Given this list of marker genes PYGL, MLLT3, MAPK14, RPUSD2, PLG, SH3BP2, SOX5, STX1A, MITF, TYMP, AQP1, CDKL5 (cyclin dependent kinase like 5), ADRB2, CFI, PIGA, ALB, SERPINC1, IL6, GCNT2 (NCBI Gene Id 880), CAMK2D, AFAP1, NBL1, PDE6A, MFSD9, RGS3, ATP1A2, here is a description of the gene set: Human Gene Set: HOEGERKORP_CD44_TARGETS_DIRECT_UP from publication Högerkorp CM, Bilke S, Breslin T, Ingvarsson S, Borrebaeck CA (PMID 12411303) studied in species Homo sapiens Genes directly up-regulated by CD44 stimulation of B lymphocytes. A number of studies have implicated a role for the cell surface glycoprotein CD44 in several biologic events, such as lymphopoiesis, homing, lymphocyte activation, and apoptosis. We have earlier reported that signaling via CD44 on naive B cells in addition to B-cell receptor (BCR) and CD40 engagement generated a germinal center-like phenotype. To further characterize the global role of CD44 in B differentiation, we examined the expression profile of human B cells cultured in vitro in the presence or absence of CD44 ligation, together with anti-immunoglobulin (anti-Ig) and anti-CD40 antibodies. The data sets derived from DNA microarrays were analyzed using a novel statistical analysis scheme created to retrieve the most likely expression pattern of CD44 ligation. Our results show that genes such as interleukin-6 (IL-6), IL-1alpha, and beta(2)-adrenergic receptor (beta(2)-AR) were specifically up-regulated by CD44 ligation, suggesting a novel role for CD44 in immunoregulation and inflammation.